Given this list of marker genes Chd7 (chromodomain helicase DNA binding protein 7), Fhl2, Rbpj, Tgfbr1, Bmp5, Bmpr1a, Fkbp1a, Nkx2-5, Notch1, Egln1, Sfrp1, Tgfb2, Cyp27b1, Vdr, Ppargc1b, Wnt10b, Foxh1, Fbn2, Srf, Ext1, Adamts1, Msx2, Thbs3, Chad, Bmp10, Cav3, Bmp7 (bone morphogenetic protein 7), Sema4d, Med1, Dll4, Enpp1, Vegfa, Sos1, Ovol2, Tek, Rhoa, Col1a1, Adgrg6 (NCBI Gene Id 68901), Fgfr3 (NCBI Gene Id 14184), Hey2, Eng, Grem1, Nfatc1, Sbno2, Hey1, Slc40a1, Nrg1, Ccm2l, Smarca4, Heg1, Tgfbr3, Ube4b, S1pr1, Nog, Mmp2, Rbp4, here is a description of the gene set: Mouse Gene Set: GOBP_TRABECULA_MORPHOGENESIS species: Mus musculus The process of shaping a trabecula in an organ. A trabecula is a small, often microscopic, tissue element in the form of a small beam, strut or rod, which generally has a mechanical function. Trabecula are usually but not necessarily, composed of dense collagenous tissue.